The following is a description of a gene set: from publication Jiang C, Chao CC, Li J, Ge X, Shen A, Jucaud V, Cheng C, Shen X (PMID 38455971) Tissue-resident memory T cells (TRM) are a specialized T cell population residing in peripheral tissues. The presence and potential impact of TRM in the tumor immune microenvironment (TIME) remain to be elucidated. Here, we systematically investigated the relationship between TRM and melanoma TIME based on multiple clinical single-cell RNA-seq datasets and developed signatures indicative of TRM infiltration. TRM infiltration is associated with longer overall survival and abundance of T cells, NK cells, M1 macrophages, and memory B cells in the TIME. A 22-gene TRM derived risk score was further developed to effectively classify patients into low- and high-risk categories, distinguishing overall survival and immune activation, particularly in T cell-mediated responses. Altogether, our analysis suggests that TRM abundance is associated with melanoma TIME activation and patient survival, and the TRM-based machine learning model can potentially predict prognosis in melanoma patients. Human Gene Set: JIANG_MELANOMA_TRM2_CD8 studied in species Homo sapiens, and this is the list of marker genes: IFNG, RGCC, TNF, COTL1, PPP1R15A, HLA-DMA, ZFP36L1, NR4A1, FASLG, BTG2, NFKBIZ, GZMK, SELENOK, JMJD6, HLA-DQA1, TNFSF9, SRSF7, ARPC5L, GNG2, IGKV1-5, SLA, CCL4L2, CXCR4, ALOX5AP, DUSP2, HLA-DPA1, CLEC2B, UBC, HLA-B, PRNP, CSRNP1, RHOH, FABP5, RASGEF1B, TNFAIP3, PHLDA1, DUSP1, RGS2, PTPN22, CYTOR, VPS37B, TAGAP, PTGER4, GLUD1, NFKBID, HLA-DRB5, PNRC1, DTHD1, NFKBIA, SAMSN1, NR4A3, HSPA8, GADD45B, TSPYL2, CRTAM, DNAJB6, CD69, NEU1, DNAJA1, HSPH1, RBKS, GZMA, NAMPT, RSRP1, SH2D1A, DNAJB1, CKS2, CST7, CTSC, YPEL5 (yippee like 5), XCL1, SAT1, REL, IGKC, ZNF331, ICOS, DUSP4, PIK3R1, SRGN, PTPRC, GZMH, NR4A2, BHLHE40, CEMIP2, CCNH, CCL3, HLA-C, MYADM, RALGAPA1, ZFP36, FOS (Fos proto-oncogene, AP-1 transcription factor subunit), KLF6, HSP90AA1, CLK1, XCL2, HLA-DPB1, HLA-DRA, BRD2, BIRC3, SDCBP, ANKRD37, JUN, TUBA1A, RNF19A, LCP1, TUBA4A, HLA-A, CD8A, HSPA1A, APOBEC3G, H3-3B, CCL5, FOSB, ANXA1, HLA-DRB1, ID2 (NCBI Gene Id 3398), CCL3L3 (C-C motif chemokine ligand 3 like 3), TENT5C, HLA-DQB1, UBB, CREM, SLC2A3, MAP3K8, SERTAD1, HSPA1B (NCBI Gene Id 3304), LAG3, RGS1, BTG1, GBP5, CLIC1, MALAT1, CD74, CITED2, JUND, HSP90AB1, ITM2A, NKG7, CCL4, LYST, GZMB, STK17B, SRSF2, MCL1, CBLB, LSP1, CD44